Given this list of marker genes Spdya, Terb1, Lmna, Sun1, Rad21l, Terb2, Majin, Iffo1, here is a description of the gene set: Mouse Gene Set: GOBP_CHROMOSOME_ATTACHMENT_TO_THE_NUCLEAR_ENVELOPE species: Mus musculus The process in which chromatin is anchored to the nuclear envelope.